Given this list of marker genes NPY, SYT9, VPS13A, SPX, TAC1, CACNA2D1, PLCB2, MYRIP, ECRG4, CADPS, CRHBP, FZD8, DVL1, NPFF, IGF1, SLC6A9, SYT13, DMXL2, SOD1, OPRD1, CALCA, CHGA, AVP, HCRT, GNAI2, CRH, BAIAP3, ADRB2, PENK, SLC6A5, SYT8, APP, SYT7, SCG2, OXT, VPS13C, KIF1A, SST, PDYN, ADAM8, SYT4 (NCBI Gene Id 6860), ADRB1, SYT2, SYT5, P2RX2, SYT1, STXBP5, GHRL, here is a description of the gene set: Electron-dense organelle with a granular internal matrix; contains proteins destined to be secreted. Human Gene Set: GOCC_DENSE_CORE_GRANULE studied in species Homo sapiens